Given this list of marker genes ALDOB, here is a description of the gene set: part of: Diseases of carbohydrate metabolism Reactome Pathway: Hereditary fructose intolerance Deficiencies in aldolase B arising from mutations in the aldolase B gene (ALDOB) prevent the cleavage of fructose 1-phosphate to glyceraldehyde (GA) and dihydroxyacetone phosphate (DHAP), leading to hereditary fructose intolerance (HFI). This autosomal recessive disorder is potentially fatal, but can be managed by exclusion of fructose from the diet. species: Homo sapiens